Given this list of marker genes Ptpn22, Tirap, Trim3, F2rl1, Peli1, Flot1, Wdfy1, Cav1, here is a description of the gene set: Any process that activates or increases the frequency, rate, or extent of toll-like receptor 3 signaling pathway. Mouse Gene Set: GOBP_POSITIVE_REGULATION_OF_TOLL_LIKE_RECEPTOR_3_SIGNALING_PATHWAY species: Mus musculus